The following is a description of a gene set: studied in species Mus musculus Mouse Gene Set: SMARCC2_TARGET_GENES Genes containing one or more binding sites for (Smarcc2) in their promoter regions (TSS -1000,+100 bp) as identified by GTRD version 20.06 ChIP-seq harmonization. from publication Yevshin I, Sharipov R, Kolmykov S, Kondrakhin Y, Kolpakov F (PMID 30445619), and this is the list of marker genes: Gm13264, Gm10115, Gm12684, Slc25a19, Tmc3, Colgalt2, Tmtc1, Ankrd13a, Syde2, Smad5, Trbv12-2, Gm9899, Gm807 (NCBI Gene Id 328320), Defb19, 1500005C15Rik, Zfp248, Fgfr3, Krtap13-22 (NCBI Gene Id 69661), Timd2, Ubap1, Skida1, Vrk2, Or8u9 (olfactory receptor family 8 subfamily U member 9), Pds5a, Gm7467, Wnt5a, Gm7676, St3gal6 (NCBI Gene Id 75513), Gna15, Frmd4a, Alox12b, Gm22777, Grsf1, Atxn7l1, Rab11fip4, 2310075C17Rik, Prss51, Tmem80, Ndnf, Atxn2, Acvr1, Cldnd2, Gask1b, Mboat1, Spata46, Tlr1, Themis, Taok3, Gas1, Gng5, Vgll4, Gm11292 (predicted gene 11292), Gm15419, Ulk4, Gm9364, Gbp9, Gm9951, Slc25a16, Hif1a, Tcf4, Lama4, Kansl2-ps, Ttyh3, Tmcc3, Ythdc2, Nxnl2, 1700104B16Rik, Pax6, Kcnn3, Gm6587, Proser1 (NCBI Gene Id 72683), Dlgap3, Slco2a1, Shcbp1l, Gm12369, Dnah6, Glrx5 (NCBI Gene Id 73046), Zfp385c, Adgre1, Or2y11, Mfrp, Wdr75, Nynrin, Gm31274, Dclk1, Spopl, Tnfrsf10b, Ttll11, Kifc3, Adamtsl1, Lamp5, Oit3, Tex24, Zfp939, Macroh2a1, Gm2622, Tbc1d20, Gm15326, Pcnx2, Vmn1r49, Slc39a3 (NCBI Gene Id 208667), Selenop, Efr3b, Pid1, Kcnip4, Sh3tc1, Gm23950, Ensa, Gm11371, 1700074A21Rik, Mucl1, Sstr4, Cbfa2t2-ps1, Miga2, Gm14020, Cox19, Nkx3-1, Or7e166, 4930512H18Rik, Tbc1d1, Tfeb, Plekha3, Tecta, Ephx1, Dmrt2, A330048O09Rik, Pwwp2a, Cfap61, Foxm1, Cnbd2, Pax8, Kcnv2, Rbm27, 4930474N05Rik, Becn2, Il21r, Gm14461, Vmn2r4, Ank1, Def8, Jkampl, Fmo2, Actc1dt, H2bl1, Palld, Gm12709, Sntg1, Gm8304, Atp6v0a1 (NCBI Gene Id 11975), Rhno1, Ccdc30, Gbp8, Sult1d1, Sgip1, Spop, Mir7066, Gm13658, Lrrk2, Fam53b, Klhdc1, Gm26688, Flt1, Sva, Gsr, Trpm4, D030055H07Rik, Usp17lb, Hkdc1, Islr, Gdnf, Hsd17b13, Ptges, D430018E03Rik, Lcmt1, Mir138-1, Smcp, Pkhd1l1, Appl1, Fam174b, Wfdc3, Sele, Gm11855, Thsd7b, Nwd2os, Abtb3, Ptpn14 (protein tyrosine phosphatase, non-receptor type 14), Gm29083, Cdh19, Gramd1b, Gm23131, Gm9915, 4933439C10Rik, Chaer1, Bach2, Pdcd5, Add3, Gm29455, Crtc2, Gm35202, Gykl1, Cplx2, Gipc2, 1600019K03Rik, A930003O13Rik, Ank3, Tdpoz3, Ppm1l, A330023F24Rik, Thbs4, Gbx1, Nfe2, Mrps9 (NCBI Gene Id 98691), Slc6a11, Ccdc85a, Dytn, Dlg5, Paqr5, Mir100hg (NCBI Gene Id 99733), Pdzrn3, Gm14065, Dusp21, Ampd3, Pld1, Gm33973 (predicted gene, 33973), 4933416E03Rik, Gm14887, Gm17210, Nr6a1, Fxyd4, Mmp3, Lsm14a, Gpr26, Tnni3k, Tmod1, Fbf1, Spp1, Ccdc122, Best1, Ccl24, 6030445D17Rik, Bmf, Spata19, Cep112, St8sia1, Gm26263, Frem1, Sec24d, Nxpe5, Gdpgp1, Ppp2r5a, Pptc7, Cacng3, Gucy1b1, Sowaha, Entpd8, Ccdc141, Iqcg, Gm24981, Clcn3, A230004M16Rik, Siglecl2, Calr4, Gm26878, Celf2, Hvcn1, Ppp1r3g, Speg, Zfhx3, Fmc1, Kctd10, Slc7a2 (NCBI Gene Id 11988), Kalrn, Prr5l, Spaca1, Vcam1, Psen2, Sh2d7, Inpp4a, 2610307P16Rik, B930094E09Rik, Phf24, Senp7, 4930562C15Rik, Gm35065, Gpr27, Ecpas, 1700034E13Rik, Cdc42ep5, Slc10a7, 4930478K11Rik, Gm25726, Slc1a2 (solute carrier family 1 (glial high affinity glutamate transporter), member 2), Or8b1c, Alox5ap, Doc2a, Samd4, Fkbp6, Aldoa, Celsr1 (NCBI Gene Id 57075), Fap, Cib1, Or5m13, Lamc2, Rsad2, Tenm2, Paip1, Scn1b, Kif9, Icmt, Cnpy3, Efemp1, Nsun2, Acacb, Gm17182, Map3k14, A730018C14Rik, Gm32496, Gm24623, Nfib, Cdh26, Gm25877, Mir9-2hg, Gm26006, Fut9, Adamtsl3, Ttyh1, Dnai2, Gm7967, Il10rb, Rrad, Crem, 1700120G11Rik, Cd22, 1700110C19Rik, Alkal1, Fam83g, Hmgb1, Akap7, Daglb, Or6c8b, Spaca3, Asic2, Myo5a, Or2y6, Rin3, Rftn2, Tfap2e, Apool, Gm34411, Avpr1a, Arap2, Cnppd1, Tnfrsf13b, Ttll4, Gm24152, Ttll6, 1700042G15Rik, Zfp385b, Smc5, Klhdc8a, Ptger3, Rergl, Gm36793, Gimap7, Gm23324, Or4k40, Gm15503, Pdlim4, Snta1, Vmn1r44, Maco1, Gm22836, Or6c38 (olfactory receptor family 6 subfamily C member 38), Dnase1l3, Ttll7, Lmo3, Macf1, Samd7, Wipf3, Gm8220, Ltf, Usp17ld, Islr2, Kif23, Kcnip3, Pcid2, 2900079G21Rik, Sycn, Celf4, Phlda3, Smim14, Fam81a, Atg4a, Myo1h, Thsd7a, Gm13005, Gm26592, Rps4x-ps, Lsamp, Asns, Gm5259, Osbpl1a, Slc6a15, Selplg, Gm15834, Srgap1, Slco1a5, Gm16876, Foxi1, Ino80c, Tmem144, Mir3095, Tas2r104, Gm8482 (predicted pseudogene 8482), Pla2g10, Ccn3, Sp6, Akr1b8, Rai1, Iqank1, Gm24469, Cln6, Serpinb6e (serine (or cysteine) peptidase inhibitor, clade B, member 6e), Lix1, Carmil1, Gm14330, Rgs16, Scn5a, Slc1a3, Gm9947, Gpr85, Col5a2, Mbip, Col28a1, Cp, Tnfaip8, Parva, Gm24398, Mb, Upp2, Car14, Wnt11, Or2w2, Slc19a3, Homer3, Prok2, Synj2bp, Gm26820, Gbp4, Gm26744, Cacnb4, 2310022B05Rik, Gm12244, Alpl, Dgat2, Phlda1, S2bpcox16 (NCBI Gene Id 105940408), Gm23534, Cers3, Kbtbd11, Rps15, Zfp786, Gm5855, Gm13187, Gria2, Epb41l1, Por, Zan, Gm12837, Gm25721, Sec31a, Nhlrc3, Capn1, Clic5, Or4c119, Or2bd2, Pxn, Gm27243, Serpina1e, Slc34a2, Ntpcr, Crxos, Gm23194, Spx, Gm13337 (NCBI Gene Id 637235), Cmas, B230317F23Rik, Vmn2r7, Zfp867, Gm10212, Grin2b, Igf1, Prr15l, Wscd2, Dipk2b, 1700006F04Rik, Dhdh, Or4k38, Spink10, Gm24902, Zfp777, A330058E17Rik, Gm11370, Zkscan17, Hspd1-ps4, Papolg, Gm10764, Mxra7, Gtf2e2, Gm20162, Mir181a-2 (microRNA 181a-2), Atp2b2, Kmt2b, Dnah7b, Gm26468, Ak5, P3h2, Ube3a, Myo18b, Garnl3, Ubr1, Zbtb20, Pmp22, Meikin, Nexn, Oasl1, Me2, Eif4ebp1, Zfhx2, Gm12998, Memo1, Fancd2, Gm26138, Letm1, Gm15794, Fbxo36, Wdr24, Gm8980 (predicted gene 8980), Zfp592, Gm12217, Rhoh, C2cd2, Lacc1, Dnaaf3, Nup210, Gm30484, Car5a, Ssbp1, Fam234b, Hrc (histidine rich calcium binding protein), Eml1, Cimip2b, Or8g2b, Lrrc36, Gm5570, Arhgap28, Mir7654, Tex13a, Gm15170, Lrrc8d, AW554918, Gm18697, Chrm3, Gm23852, Ptprn, Tcap, Mir146b, Selenon, Trim32, Astn1, Hdac7, 2010009K17Rik, Gm27198 (predicted gene 27198), 4933427E13Rik, Cped1, Rnf128, Nt5c3, Gm13787, Slc11a2, Cacna1e, 4930412B13Rik, Ttn, Or7e175, Bag2, Gm12468, Myo1c, Shisa9, Smap2, Trim29, Or13a26, Stau2, Dnttip1, 1700047M11Rik, Arhgap19, Svep1, Gm13446, Pcdh20